The following is a description of a gene set: Mouse Gene Set: GOBP_REGULATION_OF_PLASMINOGEN_ACTIVATION Any process that modulates the rate, frequency or extent of plasminogen activation. Plasminogen activation is the process in which plasminogen is processed to plasmin. studied in species Mus musculus, and this is the list of marker genes: Plaur, Ctsz, Anxa2, S100a10, Plgrkt, Clec3b, Serpine2, Thbs1, Eno1, Plat, Serpine1, Serpinf2, F12, Eno1b, Plau, Hpn, Cpb2, Meltf